The following is a description of a gene set: from publication Chen Y, Wang X (PMID 31504780) studied in species Mus musculus Genes predicted to be targets of miRBase v22 microRNA mmu_miR_880_5p in miRDB v6.0 with MirTarget v4 prediction scores > 80 (high confidence targets). Mouse Gene Set: MIR_880_5P, and this is the list of marker genes: Tmem50a, Rnf216, Syce1, Srpk2, Zfp317, Pacsin2, Cd226, Taok1, Fhod3, Rerg, Adnp, Wfs1, Ado (NCBI Gene Id 211488), Igf2bp3, Tmem59l, Myof, Cfap97d2, Parp9 (NCBI Gene Id 80285), Srsf3, Isoc2a, Creb3, Abca8b, Spcs3, Slit3, Slc17a3, Pcdhb11 (protocadherin beta 11), Senp6, Tcf4, Plau, B230219D22Rik, Marchf8, H3f5, Gm7694, Pappa, Gnpnat1, Shc4, Arl11, Sik3, Naa15, Kif5b, Kcnd1, Nras, Aida, 5031439G07Rik, Ppp4r2, Cyria, Sertm1, Prodh, Zfp148 (NCBI Gene Id 78647), Desi2, Ptgr2, Pclo, Mtap (methylthioadenosine phosphorylase), Ube2e3, Ctnna1, Gabra5, Itsn1, Ankrd6, Krt14, Arid2, Lgr5, Ndufc2, Tgfbr1, Zfp518b, Gsr, Unc5d, Nomo1, Fabp12, Eif4e (NCBI Gene Id 668879), Ankle2, Slc9a6, Cops8, Oxsm, Lrp1b